The following is a description of a gene set: Genes defining the Mycobacterium tuberculosis strain-independent regulatory axis of the host macrophage cells. studied in species Homo sapiens from publication Kumar D, Nath L, Kamal MA, Varshney A, Jain A, Singh S, Rao KV (PMID 20211141) Human Gene Set: KUMAR_AUTOPHAGY_NETWORK We performed a genome-wide siRNA screen to identify host factors that regulated pathogen load in human macrophages infected with a virulent strain of Mycobacterium tuberculosis. Iterative rounds of confirmation, followed by validation, identified 275 such molecules that were all found to functionally associate with each other through a dense network of interactions. This network then yielded to a molecular description of the host cell functional modules that were both engaged and perturbed by the pathogen. Importantly, a subscreen against a panel of field isolates revealed that the molecular composition of the host interface varied with both genotype and the phenotypic properties of the pathogen. An analysis of these differences, however, permitted identification of those host factors that were invariantly involved, regardless of the diversification in adaptive mechanisms employed by the pathogen. Interestingly, these factors were found to predominantly function through the regulation of autophagy., and this is the list of marker genes: PDK1, TOP2A, CENPK, ZNF831, LINC02870, LAMB1, KERA, PLEKHG2, MSMP, RTF2, P2RY13, ABTB2, LST1, HNRNPC (NCBI Gene Id 3183), MRPL20, KLHL11, PDZD11, ZNF599, CPS1, RELL1, GAL3ST3, HCAR2 (hydroxycarboxylic acid receptor 2), SLC26A11, VPS26B, ZNF554, FRMD5 (FERM domain containing 5), LCOR, LGALS9, FUCA2, CARD17P, GATD3, TLCD4, KRBA1, ENTREP3, PGM1, ACTL6B (actin like 6B, NCBI Gene Id 51412), PGK1, DPY30, BMP1, RIMS2, DIRAS1, CPZ, REV3L, GUK1, ACAT2, EMP2, TLR8, NAT16 (N-acetyltransferase 16 (putative)), ZNF416, CNN1, CRX, USP9Y, FGF23, LETM2, HCP5, PROK2, MAPK10, IRF4, MOCS2, GALNT2, ST8SIA4, TFAP2C, VCP, MRPL3, CDH6, PRXL2C, KLRF1, ARPP19, LTBP4, PXK, NEK7, CDAN1